Given this list of marker genes Hipk2, Cryaa, Phactr4, Cited2, Arid1a, Aldh1a1, Sp3, Aldh1a3, Zeb1, Ihh, Six3, Foxf2, Hipk1, Ift122, Pax2, Kdm2b, Th, Lrp6, Pax6, Frs2, Sox11, Bmp7 (bone morphogenetic protein 7), Stra6, Tfap2a, Twist1, Prox1, Ift172, Fzd5, Sp1, Tbx2, here is a description of the gene set: Mouse Gene Set: GOBP_EMBRYONIC_CAMERA_TYPE_EYE_MORPHOGENESIS The process in which the anatomical structures of the eye are generated and organized during embryonic development. species: Mus musculus